The following is a description of a gene set: species: Homo sapiens An elevated concentration of follicle-stimulating hormone in the blood. Human Gene Set: HP_ELEVATED_CIRCULATING_FOLLICLE_STIMULATING_HORMONE_LEVEL Elevated circulating follicle stimulating hormone level, and this is the list of marker genes: NR5A1, FIGLA, BMPR1B, CBX2, CYP11A1, GDF9, SOX9, HROB, SHOC1, AR, POR, VAMP7, SYCP2L, PPP2R3C, LHB, CNBP, DIAPH2, WWOX, CLPP, WT1, FKBP6, NSMCE2, ZMYND15, MSH4, CYB5A, STAG3, FGD1, GATA4, XRCC2, MEIOB, ESR2, KASH5, GCNA, ZSWIM7, FOXL2, MCM8, C14orf39, TP63, MAP3K1, HFM1, PSMC3IP, DHX37, CYP17A1, SRY, KISS1R, ERCC6, FANCM, NR0B1, MSH5, SPIDR, BNC1, MCM9, SPATA22, SOHLH1, ZFPM2 (NCBI Gene Id 56958), MRPS22, TAF4B, SLC30A7